The following is a description of a gene set: Human Gene Set: MIR4638_3P Genes predicted to be targets of miRBase v22 microRNA hsa-miR-4638-3p in miRDB v6.0 with MirTarget v4 prediction scores > 80 (high confidence targets). from publication Chen Y, Wang X (PMID 31504780) species: Homo sapiens, and this is the list of marker genes: PAQR8, ATXN1, SEC63, TNFSF15, CACNA1D, YY1, PLEKHM3, TOLLIP (toll interacting protein), PEX11A, ALCAM, ZNF674, ACVR1, KCNC3, RBMS2, FZD2 (NCBI Gene Id 2535), CCDC144NL, RBFA, ITPRID2, PKN2, RALGAPB, C5orf63, KLHL21, POMGNT1, TUBB, TFAP2B, WDR37, PAXBP1, TRIL, GLOD4, AK9, GALNT3, EDRF1, MAL2, NFRKB, KMT5B, THRB, XRN1, CHORDC1, CACNB2, ANK3, PSMA8, CELF4, GPR173, WDR17, NAA15 (N-alpha-acetyltransferase 15, NatA auxiliary subunit), INHBC, TNFRSF18, SETD3, FBXW11, CCK, TGFBR3, NFIA, CPEB1, KNG1, VANGL1, CAMK1D, NADK, MOXD1, POLR2G, DISC1, NKAP